Given this list of marker genes Fgf13, Zfp106 (NCBI Gene Id 22647), Aagab, Zfp334, Pcyt1b, Fastkd2, Rag1, Tubgcp4, Epop, Prtg, Cachd1, Arl6ip6, Arid1b, Prex2, Il13, Tnrc6b, Nectin3, Carf, Map3k1, Riox2, Osbp, Gns, Rc3h2 (ring finger and CCCH-type zinc finger domains 2), Pigg, Scn9a, Zkscan8, Timmdc1, Cxcl10, Itga9, Ppp3r1, Bdp1, Epm2aip1, Tob1, Ranbp9, Mettl9, Tspyl1, Ppp4r3c2, Creb1, Ssbp3, Wdr81, Chl1, Ebna1bp2, Rbbp6, Ythdf2, Ddi2, Ankzf1, Qrich1, Ppp4r2, Taf4b, Ccdc68, Ccnt2, Slc17a8 (solute carrier family 17 (sodium-dependent inorganic phosphate cotransporter), member 8), Ccpg1, Skil, Chn2, Ephx1, Cd164, Cadm2, Ptprk, Ocrl, Pkhd1, Cd44, Tle3 (NCBI Gene Id 70332), Gemin5, Nup153, Foxd2, Ammecr1, Arl4a, Gid4, Kdm7a, Sppl3, Stag2, Tmem265, Grm5, Tmem218, Arrdc3, Mapk1, Ergic1, Trib2, Btg2, Patz1, Rgs7bp, Ppp3ca, Tardbp, Rbbp5, Asic2, Cdk5rap1, Kctd12, Crispld1, Zfp108, Rap1a, Zfp78, Nck1, Dnm1l, Gnb1, Mocs1, Usp27x, Susd5, Pcmtd1, Zcchc4, Bend3, Cd38, Pdcd6ip, Nrsn1, Chrna7, Kpna3, Scaf8, Mctp1, Csnk1g3, Thbs1, Ces1e, Cplx4 (NCBI Gene Id 225644), Rgs13, Unkl, Pea15a, Nedd9, Macrod2, Nr2f1, Cog2, Nagk, Crem (cAMP responsive element modulator), Plekhd1, Isx, Atxn1, Tars1 (threonyl-tRNA synthetase 1), Pard3b, Csn2, Zfp449, AI429214, Ctdspl2, Fam110c, Nsd2, Il12b, Atp8b1, Fam135a, Arl15, Itch, Poldip3, Wnt5a, Bloc1s2, Slc2a1 (NCBI Gene Id 20525), Il36a, Krtap16-3, Ppp1r9a, Panx1, Slc36a4, B230217C12Rik, Dazl, Hmgcr, Cdr1, Chfr, Fgfr1op2, Nat8f2 (N-acetyltransferase 8 (GCN5-related) family member 2), Khnyn, Cggbp1, Stxbp5l, Adamtsl3, Elmo1, Map3k20, Fmo1, here is a description of the gene set: species: Mus musculus from publication Chen Y, Wang X (PMID 31504780) Genes predicted to be targets of miRBase v22 microRNA mmu_miR_7048_3p in miRDB v6.0 with MirTarget v4 prediction scores > 80 (high confidence targets). Mouse Gene Set: MIR_7048_3P